The following is a description of a gene set: Mouse Gene Set: REACTOME_SYNTHESIS_OF_VERY_LONG_CHAIN_FATTY_ACYL_COAS studied in species Mus musculus Synthesis of very long-chain fatty acyl-CoAs, and this is the list of marker genes: Elovl3, Hsd17b12, Acsl3, Elovl1, Hsd17b3, Acsbg2, Elovl6, Tecr, Acsl1, Elovl7, Tecrl, Acsl6, Hacd3, Hacd2, Hacd4, Acsl4, Elovl2, Elovl5, Acsl5, Acsf3, Acsbg1, Hacd1